The following is a description of a gene set: Genes predicted to be targets of miRBase v22 microRNA hsa-miR-26a-1-3p in miRDB v6.0 with MirTarget v4 prediction scores > 80 (high confidence targets). studied in species Homo sapiens from publication Chen Y, Wang X (PMID 31504780) Human Gene Set: MIR26A_1_3P, and this is the list of marker genes: CDK6, CASK, PLB1, RIMKLB, ZNF268, CALCOCO2, ATP2B3, ZNF630, IDE, MAP7D3, CETN1, FLRT1, HOXC8, CCDC62, GLUD2, LINC01517 (long intergenic non-protein coding RNA 1517), PPARGC1B, FAM177A1, TCF7L2, ASB8, CACNA2D1, NOTCH2NLA, ANKHD1, ZNF782, AHCYL2, ZFP82, CYREN, AFF2, ACSBG1, ZNF143, DMRTA1, KRT27, CCDC73, PTBP3, ENPP5, SLC35F1, ADGRF5, EML6, TBR1, SEL1L3, DNAJB4, SMARCE1, ODF2L, LRRC15, EVI2A, EIF5A2, POTEA, PPP1R21, RSBN1L, AKIRIN1, BNIP3, MTPN, OGT, C5orf63, VKORC1L1, RTL3, DMRT3, SYNCRIP, ZNF568, TMEM245, USP6NL, PABPC5, TSC1, ZFAND6, GLUD1, ST8SIA3, DCHS2, KCND2, LILRA1 (leukocyte immunoglobulin like receptor A1), MAOB, CTNND2, GCSH, S1PR1, DPYSL2, EFNA5, SLC4A4, RBM44, LRRC19, FOXJ3, MTBP